The following is a description of a gene set: studied in species Homo sapiens part of: PI Metabolism Under conditions of cellular stress, nuclear levels of phosphatidylinositol-5-phosphate (PI5P) increase. Type I phosphatidylinositol 4,5-bisphosphate 4-phosphatase TMEM55B translocates to the nucleus under stress via an unknown mechanism and generates PI5P from the PI(4,5)P2 substrate. The level of PI5P in the nucleus is kept low because of the phosphatidylinositol-5-phosphate 4-kinase activity of nuclear PIP4K2 dimers, mainly dimers containing PIP4K2B. Under conditions of cellular stress, nuclear PIP4K2B is phosphorylated and inactivated by p38 MAP family kinases. Reactome Pathway: Synthesis of PIPs in the nucleus, and this is the list of marker genes: PIP4K2C, PIP4K2B, PIP4P1, PIP4K2A